Given this list of marker genes SPHK1, ACER3, PCBD1, AGK, SPTSSB, SPR, ASAH2, ABCA2, QDPR, PLPP1, DEGS2, ACER1, LRP2, GBA1, ASAH1, PRKG2, SPTLC3, SPTLC2, NAAA, GCH1, SPHK2, PTS, DHFR, SGPP2, SGPP1, PCBD2, ACER2, PLPP2, SPTLC1, PLPP3, NOS3, SPTSSA, DHFRP1, here is a description of the gene set: studied in species Homo sapiens The chemical reactions and pathways involving a diol, a compound that contains two hydroxy groups, generally assumed to be, but not necessarily, alcoholic. Human Gene Set: GOBP_DIOL_METABOLIC_PROCESS